The following is a description of a gene set: We investigated at which stage of maturation commitment to a stable Foxp3-expressing phenotype takes place. We assessed stability of Foxp3 expression in thymic Foxp3+ Treg subsets of different maturity, defined by CD24 expression. Next we compared gene expression profiles of Foxp3+ Treg subsets (+) of different maturity (24lo, 24int, 24hi) and could identify a set of genes that were specifically up or downregulated in Foxp3+ Tregs, but not in Foxp3- conventional T cells, in a maturation-dependent manner. species: Homo sapiens from publication Toker A, Engelbert D, Garg G, Polansky JK, Floess S, Miyao T, Baron U, Düber S, Geffers R, Giehr P, Schallenberg S, Kretschmer K, Olek S, Walter J, Weiss S, Hori S, Hamann A, Huehn J (PMID 23420886) Genes down-regulated in T reg: peripheral lymph nodes versus thymic CD24 int. Human Gene Set: GSE42021_TREG_PLN_VS_CD24INT_TREG_THYMUS_DN, and this is the list of marker genes: SQOR, DOCK4, LAMP3, SP110, RNF19B, STAT3, LXN (latexin), PANX1, CTSS, MTF2, LEPROTL1, BCO1, ISG20, TCIRG1, HEG1, UBE2Z, SLC25A22 (solute carrier family 25 member 22), CXCL2 (C-X-C motif chemokine ligand 2), IFIT3, CTNNBL1 (catenin beta like 1), SAMHD1, LAP3, TEAD4, PSME2, TRAFD1, BTN3A2, PML, OAS2, IDO1, TYMP, MREG, CTSC, ZNF277, HLA-J, PLS3, TAPBP, DENND5A, PSMA4, SPATS2L, IFI44L, CD74, APOL6, KLF4, ZNF22, GSTK1, SLC14A2, IFI27, SOD2, CDK18, PLAAT4, DRAM1, C1S, SP140L, PJA1, UBE2L6, APOL3, IFI44, PARP12, ERLIN1, TGM2, IRF8, OAS3, HLA-G, PLSCR1, OCM2, BTN3A1, MYD88, CALCOCO2, TNFRSF1B, ADAR, MIR124-1HG, IFI30, STAT1, HLA-F, RNF114, CD47, CASP1, CFH, TAP2, IFIT5, PELO, PLAUR, TRANK1, OAS1, CA11, IFITM1, EIF3M, LY6E, RTP4, FZD10, ISG15, ATP10D, BATF3, TLR3, ITM2B, TXNL4B, DNPEP, C5orf15, SMARCA5, NBN, PSMB8, DDX60, MCL1, IRF3, WARS1, LTBR, HPGDS, C1R, PSME1, UBA7, FOSL2, PMAIP1, SAT1, USO1, TAP1, CASP7, CCR8, JAK2, KDM6A, GSTO1, TRIM38, TRIM14, FAS, PSMA3, NFE2L3, GBP2, IFI16, SEMA3F, RFX5, SLC25A28, TRIM31, APOL1, ZNF7, NAMPT, HLA-B, ST8SIA4, CASP4, GUK1, RIGI, GCH1, RIPK2, IRF9, OGFR, ERAP1, OPTN, IFIH1, PSMB9, TRIM25, LGALS3BP, CD38, APOL2, NMI, IRF1, IFIT1, TASOR2, HLA-C, BTN3A3, PSMB3, RBM7, UBE2D3, C3, IGFLR1, GBP1, FLT3LG, TRIM22, TRIM21, SECTM1, IL32, SHFL, BST2, MX1, CASP8, HLA-E, CFB, NUCB1, SERPING1, RBCK1, PSMA6, ADAP1, ZFP36, NPC1, PSENEN, RARS1, SP100, PARP3, CDC42EP4, FAM111A, HLA-A, PCM1, IFI35, TAPBPL, CTSL (cathepsin L), MAX, ERAP2, B2M, MX2, PSMB10, ADGRE1, PHF11, OASL